The following is a description of a gene set: species: Homo sapiens Increased skull ossification An increase in the magnitude or amount of ossification of the skull. Human Gene Set: HP_INCREASED_SKULL_OSSIFICATION, and this is the list of marker genes: HHAT, SGSH (N-sulfoglucosamine sulfohydrolase), VCP, HGSNAT, RBL2, OSTM1, NAGLU, CSF1R